The following is a description of a gene set: species: Mus musculus from publication Chen Y, Wang X (PMID 31504780) Mouse Gene Set: MIR_7235_3P Genes predicted to be targets of miRBase v22 microRNA mmu_miR_7235_3p in miRDB v6.0 with MirTarget v4 prediction scores > 80 (high confidence targets)., and this is the list of marker genes: Ankrd63, Tbl1xr1, Ankrd46, Sub1, Gfod2, Fmo9, Gsk3b, Dnah5, Prokr1, Cnr1, Dock5, Pcdh15, Enkur (enkurin, TRPC channel interacting protein), Qki, Slc7a14 (NCBI Gene Id 241919), Tmprss4, Cttnbp2nl, Ankrd33b, Lnpep, Jph4, Hook1, Epor, Fkbp14, Cab39l, Nup153, Cnbp, Xlr, Zfp146, Ube2d3, Ugt2b34, Baz2a (bromodomain adjacent to zinc finger domain, 2A), Nsrp1, Ccdc125, Muc15, Lin7a, Sorcs3, Clcn6, Pirt (NCBI Gene Id 193003), Tln2, Xylb, Serpinb2, Ccn2, Marchf7, Mpzl1, Gabra4, Taf5, Fbxl17, Frmd4b, Tial1, Padi3, Cyp11b1, Oscp1, Ddx46, Aldoc, Rab18, Ankfy1, Fabp12, Tspyl1, Csnk2a1, Lztfl1, Irf9, Rhoa, Washc4, Robo2, Grk5, Uso1, Arhgap42, Rap2a, Spata13, Prkcb, Nup98, Gm5591, Abt1, Cd2ap, Mrtfb, Htr2c, Slc39a10, Wnt8b, Arnt2, Ncbp2, Mblac2, Ankrd13c, Pde8b (phosphodiesterase 8B), Npy5r, Nms, Il17rd